The following is a description of a gene set: species: Homo sapiens Any process that activates or increases the frequency, rate, or extent of interleukin-1 alpha production. Human Gene Set: GOBP_POSITIVE_REGULATION_OF_INTERLEUKIN_1_ALPHA_PRODUCTION, and this is the list of marker genes: S100A13, IL16, NLRP10, P2RX7, PANX1, CALCA, ISL1